Given this list of marker genes Etnk1, Pcyt1a, Chka, Cept1, Sgpl1, Etnk2, Pcyt1b, Chkb, Ptdss2, Pisd, Pcyt2, Pemt, Chpt1, Ptdss1, here is a description of the gene set: species: Mus musculus Mouse Gene Set: WP_KENNEDY_PATHWAY Kennedy pathway